Given this list of marker genes NOD2, TUBB4B, ABCB10, CENPI, BLMH, RNF115, SLC30A5, AURKB (NCBI Gene Id 9212), SPTY2D1, TMEM147, FNTB (farnesyltransferase, CAAX box, subunit beta), GTF2A2, MED27, H1-10, IRF2, SPNS1, BIN2, CENPW, MAN1A2, GOLGA3, EPCAM (epithelial cell adhesion molecule), PRR14, SLC39A9, N4BP2, SMAD7, PFDN6, TMEM41A, TRIM16, PARPBP, IDH3G (isocitrate dehydrogenase (NAD(+)) 3 non-catalytic subunit gamma), ME2, CBR1, TMEM59, NDUFA3, MCL1, MYB, GMNN, CDK4, NFE2L1, C16orf54, UHRF1, GAPDH, HEXA, DCLRE1A, KPNA2, SHC1, PCTP, MCC, PSMB1, MRPL37, PSMD9, CABLES1, SLC43A3, GPR108, RNF181, PGRMC2, SDF2L1, GOT2, KCTD20, DUSP16, ARHGDIA, NOA1, ITGAL, NCAPH, TSFM, UBAP2, CPSF3, AACS, NDUFAF1, UBE2J1, PSMA5, ZC3HAV1L, CDC34, FASTKD3, C4orf46, CTSD, TMEM223, HERC2P9, EML5, TIMP2, UFM1, CD59, NEIL3, SLC37A3, H2BC10, BRPF3, SLC25A3, NELFE, H2BC6, MTRR, AARS1, SEPTIN2, CSRP1, MRPL51, MIF, ERC1, PPP1R15B, EMC7, ECH1, H4C4, MANEAL, MLST8, TPRG1, SEC24C, ZDHHC9, PLK4, TOP1, H3C3, STX11, ATF2, HJURP, DAXX, NDUFB4 (NCBI Gene Id 727762), LARP4, GID8, ELOB, HDGF, SIL1, BAK1, RDH10, MRPS15, ISOC2, MDH1, COPZ1, MRPL20, ATG2A, ALG8, HIP1, ATP6AP2, C15orf39, SSR1 (signal sequence receptor subunit 1), TMEM167A, CCNE2, RAB39B, TK2, COX18, FXN, KRTCAP2, GNL2, ZWINT, SUCLG1, SIRT2, ICAM2, PIK3C2A (phosphatidylinositol-4-phosphate 3-kinase catalytic subunit type 2 alpha, NCBI Gene Id 5286), CDKN2A, SUCLA2, CDC25B, IARS1, YIPF5, IBTK, FAM53C, MLEC, CDHR3, ADRM1, NDUFB10 (NADH:ubiquinone oxidoreductase subunit B10), COQ9, MOSPD1, FAM118B, PRMT5, ALDH18A1, HERPUD1, IGF1, GOLPH3L, SPC24, EDEM1, RXYLT1, MAGED2, PPAT, LAX1, HMBS, PLD3, PRRC1, RAP2A, NUP62CL, KDELR3, PSMC4, TOP3A, YIPF1, JMJD8, LIN52, GALK2, CDR2, NLRP14, ANXA2, CCR10, DENND1B, TMCO1, NEK2, SLC25A11, GALNT1, SDR42E1, MFSD2A, CCDC134, YIF1B, MTFR1, USP42, CYP26B1, AURKA, here is a description of the gene set: Human Gene Set: GSE20727_CTRL_VS_ROS_INHIBITOR_TREATED_DC_UP species: Homo sapiens Genes up-regulated in dendritic cells: untreated versus diphenyleneiodonium (DPI). from publication Miyazawa M, Takashima A (PMID 22974541) Identification of ROS induced genes on dendritic cells Dendritic cells were incubated for 15 min with or without a ROS inhibitor (DPI), washed extensively and incubated for 30 min with a chemical allergen (DNFB), hydrogen peroxide, and vehicle alone in HBSS containing DPI or vehicle. After washed extensively, the samples were post-incubated for 5.5 h with DNFB, hydrogen peroxide, or vehicle in complete culture medium containing DPI or vehicle.